The following is a description of a gene set: Human Gene Set: GOBP_CYTOLYSIS_IN_ANOTHER_ORGANISM studied in species Homo sapiens The killing by an organism of a cell in another organism by means of the rupture of cell membranes and the loss of cytoplasm., and this is the list of marker genes: GBP7, GBP2, CCL28, GBP3, GBP1, RNASE7, GBP5